Given this list of marker genes Rad51ap2, Wnt16, Gm30146 (predicted gene, 30146), Best1, Ism1, 3110099E03Rik, Fndc3c1, Gm24492, Dpep1, Fam151a, Gm14226, here is a description of the gene set: studied in species Mus musculus Mouse Gene Set: DESCARTES_ORGANOGENESIS_EARLY_MESENCHYME from publication Cao J, Spielmann M, Qiu X, Huang X, Ibrahim DM, Hill AJ, Zhang F, Mundlos S, Christiansen L, Steemers FJ, Trapnell C, Shendure J (PMID 30787437) Mouse Organogenesis Cell Atlas (MOCA) DE_gene_main_cluster.csv, fold.change>=1.5, qval<0.05, pval<0.05